Given this list of marker genes TG, MRGPRG, C1QC, SLC6A13, TM4SF5, LYZL6, BPIFC, MMEL1, PPY, TRPM2, CYP17A1, GZMA, KRTAP10-2, BLNK, ZNF385C, RETN (NCBI Gene Id 56729), LRRC37A2, TAS2R40, SOST, CORO6 (coronin 6), NOL4L, WFDC21P, BTBD17, CAMK1G, MYL2, OR13C7, MLC1, TMPRSS13, here is a description of the gene set: Human Gene Set: MIKKELSEN_MCV6_LCP_WITH_H3K27ME3 Genes with low-CpG-density promoters (LCP) bearing the tri-methylation mark at H3K27 (H3K27me3) in MCV6 cells (embryonic fibroblasts trapped in a differentiated state). Somatic cells can be reprogrammed to a pluripotent state through the ectopic expression of defined transcription factors. Understanding the mechanism and kinetics of this transformation may shed light on the nature of developmental potency and suggest strategies with improved efficiency or safety. Here we report an integrative genomic analysis of reprogramming of mouse fibroblasts and B lymphocytes. Lineage-committed cells show a complex response to the ectopic expression involving induction of genes downstream of individual reprogramming factors. Fully reprogrammed cells show gene expression and epigenetic states that are highly similar to embryonic stem cells. In contrast, stable partially reprogrammed cell lines show reactivation of a distinctive subset of stem-cell-related genes, incomplete repression of lineage-specifying transcription factors, and DNA hypermethylation at pluripotency-related loci. These observations suggest that some cells may become trapped in partially reprogrammed states owing to incomplete repression of transcription factors, and that DNA de-methylation is an inefficient step in the transition to pluripotency. We demonstrate that RNA inhibition of transcription factors can facilitate reprogramming, and that treatment with DNA methyltransferase inhibitors can improve the overall efficiency of the reprogramming process. from publication Mikkelsen TS, Hanna J, Zhang X, Ku M, Wernig M, Schorderet P, Bernstein BE, Jaenisch R, Lander ES, Meissner A (PMID 18509334) studied in species Mus musculus